The following is a description of a gene set: Mice were immunized with PCC (pigeon cytochrome c). from publication Fazilleau N, Eisenbraun MD, Malherbe L, Ebright JN, Pogue-Caley RR, McHeyzer-Williams LJ, McHeyzer-Williams MG (PMID 17529982) Human Gene Set: GSE7548_NAIVE_VS_DAY7_PCC_IMMUNIZATION_CD4_TCELL_UP species: Homo sapiens Genes up-regulated in CD4 T cells from lymph nodes: naïve versus day 7 after immunization., and this is the list of marker genes: CXCR2, TCFL5, SWAP70, PPM1H, ATG2A, RXRA, MAST3, SRPK1, ATG9A, ZNF318, TRAF3IP3, DOK1, CYP1A1, ALDH4A1, MGRN1, GRB7, RNMT, OSBPL8, MDFIC, SLC6A1, CELF2, ART1, ZFP69B, ZBTB6, ACTR1B, NME5, PNISR, HR, TSFM, ALG8, SLC22A5, PNN, NBAS, ZMIZ1, PIK3CB, GEMIN4, GLT8D1, ARAP1, PTPN22, NOLC1, LUC7L3, GDF10, RAB40C, GNA12, COPS6, REV3L, SEPHS2, TMPO (NCBI Gene Id 7112), SLC25A36, ID3, G3BP1, PDCD6, CENPC, LSM14A, NACC2, KIAA0930, JAG2, RGL2, PTP4A2, KLF7, ABCB9, HERC2P3 (HERC2 pseudogene 3), SNAI2, MAST1, TUSC3, TROAP, OAZ2, RANBP2, STARD13, JAG1, PPIF, HDAC5, PIM2, GPR65, ABR, PHKA2, TAF5, ORC5, YAF2, KCTD7, PTEN, POP1, NUP214, RPRD2, NCKIPSD, XPC, RCBTB2, LPCAT1, SNU13, DGKA, PINK1, ARRB2, SERTAD2, TSPYL5, NFATC3, VWA5A, SHMT2 (NCBI Gene Id 6472), USP4, BCAT1 (branched chain amino acid transaminase 1), UBN1, ABCG1 (NCBI Gene Id 9619), ARID3A, IRF2BP1, ISCU, CBFA2T3, S1PR2, DSTYK, SAG, PLIN2, KLF1, PLXND1, MARF1 (meiosis regulator and mRNA stability factor 1), SLC35D2, THAP11, AAMP, PDXDC1, RCHY1, TLR5, RGS14, RWDD3, CYP4F12, RASSF2, TXNL1, TCEAL1, MBD4 (methyl-CpG binding domain 4, DNA glycosylase), C2CD3, FOXO3, PLD2, NPRL2, RHOB, TRAIP, KRT10, MED14, ZBTB48, EHMT2 (NCBI Gene Id 80735), IFNGR1, PRIM1, KAT2A, FZR1, COIL, FAM50B, CHST15, MDM1, WBP1L, MEF2C, FOXJ2, TBC1D8, PDE6G, SSTR5, ECI1, TGFBR2, FCHO1, STAM, DHRS1, MLXIP, RAB32, TLR6, PPFIBP2, ESRRA, MXD4, CSTF1, EIF2B5, RAP2A, MPG, MBNL2, DLST, PHB2, ARHGEF9, PARN, CETN3, PIKFYVE, NSDHL, DOK2, ATG14, SRCAP, RBM4B, OGG1, ALX3, OIP5, LETMD1 (LETM1 domain containing 1), ADH5, ARHGEF15, CD2BP2, HADHB, ST3GAL6, CRTC1, POLR2C, PSMD4, XPOT, MAPK8IP3, NCBP2, TOP3B, VENTXP7, PEX6, SLC33A1, GRPR, MIEF1, HMGN2, RPA1, TMEM97